Given this list of marker genes L1CAM, MT-ATP8, CYP7B1, ATL1, PAX3, SLC2A1, AP4S1 (adaptor related protein complex 4 subunit sigma 1), GPT2, NFU1, SLC33A1, RNF170, TOE1, USP8, RTN2, NT5C2, CCT5, ATP5MK, RAB3GAP2, ATP13A2, AP4E1, AIFM1, CYP2U1, MTRFR, ATP5F1E, FA2H, AP4B1, ERLIN2, CPT1C, GBA2, FARS2, DDHD1, UBAP1, SELENOI, PGAP1, BSCL2, WASHC5, SPG11, HPDL, ALDH18A1, VAMP1, SLC16A2, MAN2B1, ATP5F1D, ATPAF2, ZFYVE26, VPS37A, GBA1, ZFR, MAG, ARL6IP1, ABCA12, SPG7, HACE1, TECPR2, MARS1, SLC25A15, GAN, UCHL1, ABCD1, KIF5A, KPNA3, ATP5MC3, C19orf12, ELOVL1, KDM5C, PNPLA6, NIPA1, SPAST, CAPN1, VCP, FLRT1, ATRX, INTS8, SETX, RNF220, SPG21, REEP1, AP5Z1, MT-ATP6 (mitochondrially encoded ATP synthase membrane subunit 6), OPA1, KIF1A, ALS2, KY, ENTPD1, WDR45B, DNM1L, KLC2, MECP2, CACNA1D, TFG, PDHX, PLP1, WDR48 (NCBI Gene Id 57599), DSTYK, REEP2, PEX3, IBA57, ARSI, DDHD2, GBE1, ATP5F1A, SPART, ASCC3, RAP1GDS1, AP4M1, B4GALNT1, STXBP1, GJC2 (NCBI Gene Id 57165), ABHD16A, AMPD2, PI4KA, AMFR, LAMB1, LYST, RNASEH2B, SPTAN1, KIDINS220, HSPD1, here is a description of the gene set: Spastic paraplegia Human Gene Set: HP_SPASTIC_PARAPLEGIA studied in species Homo sapiens Complete loss of the ability to move the lower limbs accompanied by spasticity of the lower limbs.